The following is a description of a gene set: species: Homo sapiens from publication Durant L, Watford WT, Ramos HL, Laurence A, Vahedi G, Wei L, Takahashi H, Sun HW, Kanno Y, Powrie F, O'Shea JJ (PMID 20493732) Human Gene Set: GSE21670_UNTREATED_VS_TGFB_TREATED_CD4_TCELL_DN STAT3, an essential transcription factor with pleiotropic functions, plays critical roles in the pathogenesis of autoimmunity. Despite recent data linking STAT3 with inflammatory bowel disease, exactly how it contributes to chronic intestinal inflammation is not known. Using a T cell transfer model of colitis we found that STAT3 expression in T cells was essential for the induction of both colitis and systemic inflammation. STAT3 was critical in modulating the balance of T helper 17 (Th17) and regulatory T (Treg) cells, as well as in promoting CD4+ T cell proliferation. We used chromatin immunoprecipitation and massive parallel sequencing (ChIP-Seq) to define the genome-wide targets of STAT3 in CD4+ T cells. We found that STAT3 bound to multiple genes involved in Th17 cell differentiation, cell activation, proliferation and survival, regulating both expression and epigenetic modifications. Thus, STAT3 orchestrates multiple critical aspects of T cell function in inflammation and homeostasis. Genes down-regulated in CD4 T cells: medium versus TGF beta., and this is the list of marker genes: SALL2, MYO1H, TMT1A, FMO5, RAB38, FHL1, CBX7, MPRIP, PROCR, PCMTD1, NBEA, ITSN1, TPRG1L, IFIT1, ADGRA3, MAMDC2, TXNIP, MSANTD4, CERS4, MUC13, PLD3, TBXAS1, RBM4B, ITM2A (integral membrane protein 2A), AGO1, NAP1L3, CAPS2, ANKRD33B, SLA2, ACOX1, MED12L, PABPC4L, NPR2, SLC35D2, ENTPD1, IFI27, TGFBR2, PRR13, KRT18, GPRASP3, CAMSAP3, AXL, PRRC1, CDC14B, KMT2A, COL4A1, PARP14, GPRASP2, GPX7, UNC45B, SEC24C, CLN3, EYA2, INTS6L, SYDE1, ALDOC, TTLL7, FICD, IER3, SIPA1L3, TRAF1, FGD5, YES1, RNASEL, PALLD, PRDM16, SLCO2A1, SGCE, OCRL, CASTOR1, NFE2, F2RL3, TOR4A (torsin family 4 member A), IL4, GPRIN2, CASP4, INPP5A, AAMDC, EPHB6, PDE4DIP, CADPS2, RGS1, NKX2-3, MAF, SIX5, EXOC6B, LDHD, NHSL3, PHC1, KLHDC1, TNNI3, SLC16A9, CD200, ST6GALNAC5, ALDH1L1, STAT1, TTC19, DUBR, CCDC120, OXR1, MFSD8, INHA, NYNRIN, PHLPP1, TTC8, ZNF862, RBMS2 (NCBI Gene Id 5939), APH1B, PIGP, UBASH3B, EID2, ZNFX1, CSGALNACT1, PRKAA2, MBLAC2, TIE1 (NCBI Gene Id 7075), TSPAN4, CYP2D6, STXBP4, FOXO1, F11R (NCBI Gene Id 50848), RINL, PLXDC2, BACH1, USP54, MYCT1, MPL, GCH1, CRISPLD1, MPZL1, EMX2OS, PPARGC1A, RBP1 (NCBI Gene Id 5947), TMBIM1, GBP2, RND2, FGD3, DLG2, RASSF6, EFCAB14, PBX1, CILK1, TRIB3, IFIT1B, GHR, FGF11, RDH5, GTF2I, NDN, TTC3, UPP1, CDC42EP3, RAB37, VPS54, PLSCR4, ESAM, SCAI, FRY, PDZK1IP1, RAI14, SPTBN4, ATP10D, ENO2, TLE6, EHMT1, HLA-B, JADE2, COL4A2, PRRC2B, RBM5, IER5, ADAM22, MYCN, OSBPL1A, DPM1, GBX2 (gastrulation brain homeobox 2), IRF6, BCORL1, ST3GAL1, IFT43, TREML2, FSTL1, VLDLR, MTURN, PRXL2C, HACD4, WBP1L (WW domain binding protein 1 like), GLUL, LGALS4, PRKG1, TMBIM4, MTAP, SFXN4, ZNF141, TTC28, UBE2E2, PTGS1, DGKG, RASGEF1B